The following is a description of a gene set: Quizartinib is a type II tyrosine kinase inhibitor that is in phase III clinical trials for treatment of acute myeloid leukemias with FLT3 internal tandem duplications (ITDs). This pathway describes FLT3 mutants that display resistance to quizartinib. part of: Drug resistance of FLT3 mutants Reactome Pathway: quizartinib-resistant FLT3 mutants species: Homo sapiens, and this is the list of marker genes: FLT3